The following is a description of a gene set: Congenital thrombocytopenia Human Gene Set: HP_CONGENITAL_THROMBOCYTOPENIA Thrombocytopenia with congenital onset. studied in species Homo sapiens, and this is the list of marker genes: GATA1 (NCBI Gene Id 2623), HOXA11, STAT2, MECOM, MYH9, WAS